Given this list of marker genes CCN3, SPX, MGLL, GPR171, ZFHX2, NMU, FABP5, PIRT, ADORA1, SMR3A, TMEM100, CCL3, ABCB1, TAC4, TAFA4, GRM1, ATPSCKMT, TAC1, GRIN2D, ACP3, SMR3B, OPRPN, here is a description of the gene set: species: Homo sapiens Human Gene Set: GOBP_REGULATION_OF_SENSORY_PERCEPTION Any process that modulates the frequency, rate or extent of sensory perception, the series of events required for an organism to receive a sensory stimulus, convert it to a molecular signal, and recognize and characterize the signal.